Given this list of marker genes SESN1, STC1, RPRD2, ZNF605, SLC27A5, SLC35A4, PLEC, MACROD1, CAMK2G, TOP3A, B3GALNT1, GAA, S1PR4, MFNG, EMP3, RHBDL1, CTSG, GLRA4, ARHGEF18, SYNE4, ADAM28, PKP2, SIDT2, ILRUN, UTP25, COL9A3, C19orf12, GIT1, SLC17A9, CNR2, MEDAG, HSD17B1, PTOV1, LYPLA2 (lysophospholipase 2), SORCS2, APBB3, MCRIP1, CWH43, DEPTOR, STK32B, TRIB3, ECE2, MADD, ARRDC1, SMG5, PBLD, CFAP91, ACTL6B, SLFN13, MARK2, FOXA3 (NCBI Gene Id 3171), TNRC6C, ENPP4, DEAF1, NELFB (NCBI Gene Id 25920), ENTPD6, FCGR2A, RCBTB2, MTSS1, FLNA, C11orf68, PIWIL2, DNM2, TMPRSS4, FOXB1, TEC, VCAN, SAR1A (secretion associated Ras related GTPase 1A), KAZN, ZFP14, PIP5K1C, ALDH2, SLC12A7, PCDHB7, TDRP, GUCD1, GALNT10, DAXX, TUT1, DENND1A, MIB1, RASA3, GGT5, TRIP6, VAMP2, PARP8, GSX1, ESYT1, KMT2C, FGF6, ADI1, LONP1, ARHGAP45, RXRB, ARHGAP1, DDA1, AFP, G0S2, BCL11B, SEC16A, CCND3, GRK5, PCNX1, RCSD1 (RCSD domain containing 1), TGIF2, MRM1, CORO2A, NUDT6, EIF4G1, ABCC9, COL22A1 (collagen type XXII alpha 1 chain), RNF123, MYH9, ENO3, SLC2A2, GRAP2, STK10, RXYLT1, ADGRG3, IRX4, TTC3, ACSS2, TOM1, NOP56, MLX, SELPLG, TBC1D20 (NCBI Gene Id 170488), C11orf91, TRABD (NCBI Gene Id 80305), STMN3, GLB1L, TXNRD3, ITGAX, WLS, SNCA, MUC5B, XAB2 (NCBI Gene Id 56949), MSH5, ZNF23, DCLRE1B, KCNMA1, ELF5, EYA2, ADD1, CYP2S1, FBXW4, FAM174B, ARL4C, PGS1, SIX1, CRYBG1, ADCY6, GNPAT, SRPK1, FEZF2, SELL, VPS39, TMEM229B, ZNF474, CA2, NACC2, METTL17, NOC2L, C1orf159, SLC6A8, CHRNB3, ZNF526, POLR3E, RASGRP2, PHF1 (PHD finger protein 1), ACP5 (NCBI Gene Id 54), TMEM184A, C2, ESR2, KRTDAP, EMP2, CAPN15, EIF4B, FASN, SLC9A1, CYP17A1, SLIT3, MMACHC, ACOT12, ITM2A, SMPD1, CBY1, SYT12 (NCBI Gene Id 91683), TFPT, LDHB, CIDEA, UBR4, IGFBP4 (insulin like growth factor binding protein 4), UCK1, BNIPL, TRIM10, PPFIA4, TBC1D10A, AKR7A2, CARNS1, here is a description of the gene set: Genes up-regulated in tumors established by injecting MC38 cells (colon cancer): control versus CpG oligodeoxynucleotide 1826. Human Gene Set: GSE18203_CTRL_VS_INTRATUMORAL_CPG_INJ_MC38_TUMOR_UP studied in species Homo sapiens To determine the effect on gene expression of intratumoral injection of the Toll-like receptor agonist CpG1826. MC38 colon cancer cells were injected subcutaneously into C57BL/6 mice and allowed to establish until ~40 mm2. from publication Westwood JA, Haynes NM, Sharkey J, McLaughlin N, Pegram HJ, Schwendener RA, Smyth MJ, Darcy PK, Kershaw MH (PMID 19996209)